Given this list of marker genes ITGB1, ITGA6, MIR200A, ERBB4, AKT1, NRG3, MIR429, MIR200B, TNF, SFRP1, TGFB1 (NCBI Gene Id 7040), ZEB2, CLDN4, MYC, ALPL, CDH1, TERT, CCND1, here is a description of the gene set: Human Gene Set: WP_MAMMARY_GLAND_DEVELOPMENT_EMBRYONIC_DEVELOPMENT_STAGE_1_OF_4 studied in species Homo sapiens Mammary gland development: embryonic development - stage 1 of 4